The following is a description of a gene set: The gel-like material, with considerable fine structure, that lies in the matrix space, or lumen, of a mitochondrion. It contains the enzymes of the tricarboxylic acid cycle and, in some organisms, the enzymes concerned with fatty acid oxidation. Mouse Gene Set: GOCC_MITOCHONDRIAL_MATRIX species: Mus musculus, and this is the list of marker genes: Cox10, Acadl, Pptc7, Ptpn1, Nudt1, Dlat, Atad3a, Mrps21, Hspa9, Trmt10c, Acadm, Ccar2, Mthfd2, Mrpl40, Acot13, Mrps22, Rad51, Mettl17, Lrrc59, Mrps27, Mterf4, Dld, Rps3, Polg, Nipsnap1, Mrm1, Ywhag, Mccc1, Aurkaip1, Pitrm1, Mrpl17, Bola3, Coasy, Acss1, Top1mt, Pdhb (pyruvate dehydrogenase (lipoamide) beta), Mrpl41, Twnk, Mrps31, Polrmt, Mrpl47, Pccb, Dglucy, Mrpl1, Fech, Mrps18c (mitochondrial ribosomal protein S18C), Snca, Sars2, Gls, Rpusd4, Pdhx, Cps1, Mettl15, Polq, Aco2, Bckdk, Mrps17, 1700066M21Rik, Dhfr, Ngrn, Maip1, Trub2, Ttc5, Sdhaf4, Mrpl58, Acads, Nat8l, Iscu, Mrpl18, Etfa, Mrpl35, Grpel2, Capn10, Mrpl52, Mrpl3, Coq3, Aldh1b1, Pnpt1, Mrpl4, Ppif, Mrps35, Lactb2, Mrm2, Hspa1b, Mrps5, Dnajc19, Pck2, Primpol, Ears2, Nme6, Lrpprc, Hadh, Mrpl49, Acot7, Top3a, Lonp1, Mccc2, Fastkd3, Dnaja3, Tfb1m, Vdac2, Gadd45gip1, Mrpl54, Mrpl9, Dbt, Mrpl2, Dusp21, Lyrm7, Mrpl48 (mitochondrial ribosomal protein L48), Dhx30, Malsu1, Mrpl44, Dtymk, Mterf2, Mterf3, Cs, Mrpl28, Pdha1, Pcca, Ccnb1, Otc, Mrps26, Mterf1a (NCBI Gene Id 78075), Acsm1, Rida, Vdac1, Tbrg4, Dmgdh, Sirt5, Etfbkmt (electron transfer flavoprotein beta subunit lysine methyltransferase), Guf1, Mrps16, Mrps23, mt-Rnr2, Mrps18a, Ndufaf1, Pdha2 (NCBI Gene Id 229888), Slc25a5, Mrpl33, Pcx, Aldh18a1, Exd2, Grsf1, Hmgcl, Acot2, Cdk5rap1, Fastkd1, Sirt4, Pars2, Timm44, Chchd1, Mrpl24, Ogdhl, Mrpl14, Ak4, Mdh2, Hint2, Glrx2, Mrps28, Acadsb, Dnajc15, Mrpl21, Mrpl12, Trap1, Etfb, Csl, Fdx1, Nags, Alas2, Fars2, Flad1, Cox15 (cytochrome c oxidase assembly protein 15), Mipep, Mthfd1l, Shc1, Clpx, Mrps12, Acat1, Mrps9, Pdk1, Mrpl32, Ccnb1-ps, Tfam, Foxo3, Park7, Poldip2, Prorp, Uqcc2, Mrps6, Pdk4, Mpg, Iars2, Tert, Mrpl20, Nipsnap2, Atg4d, Ptcd3, Cbr4, Pin4, Pdk2, Bcl2l1, Mrpl11, Myg1 (NCBI Gene Id 80389), Fastk, Gstk1 (NCBI Gene Id 99356), Iba57, Acaa2, Mrps2, Hspe1-rs1, Mrps30, Oat, Ddx28, Ppm1k, Mrpl15, Nsun3, Sirt3, Nampt, Pgk1, Rpusd3, Cpt2, Pam16, Nars2, Adprs, Lrrk2 (leucine-rich repeat kinase 2), Mtres1, Mrpl38, Mrpl23, Alkbh7, Arhgap11a, Atp5f1b, Mettl4, Spata18, Mrps14, Tufm, Grpel1, Mrpl10, Ethe1, Mrps24, Clpp, Pdpr, Fahd1, Mtnap1, Acot9, Agxt, Tst, Echs1, Mrpl22, Mtg2, Them5, Got2, Dap3, Pde12, Coq4, Nadk2, Creb1, Hadha, Tefm, Trmt5, Nfs1, Mmut, Nsun4, Trmt2b, Bdh1, Fastkd2, Acsm2, Me3, Xrcc3, Angel2, Dlst, Ndufa10, Eral1, Nme4, Hagh, Shmt2, Mrpl57, Hadhb, Acsm5, Bloc1s1, Ndufa9, Mpv17l2, Rcc1l, Mrpl16, Mrps10, Fdx2, Mrps15, Etfdh, Polg2 (polymerase (DNA directed), gamma 2, accessory subunit), Hspa1l, Dars2, Ngb, Mrpl51, Sdhaf1, Mtg1, Hspd1, Mthfd2l, Slirp, Me2, Atxn3, Ak3, Mrpl36, Mrpl13, Pde2a, Glud1, Ssbp1, mt-Rnr1, Tyms, Mrpl34, Hsd17b10, Mrpl37, Trp53, Mrpl50, Dna2, Sdhaf3, Pdk3, Acacb, Slc27a3, Acsm3, Aldh4a1, Mrps18b, Elac2, Ivd, Sod2, Prodh, Casq1, Mrpl42, Aldh2, Cdk1, Acadvl, Mrpl53, Mrps7, Rexo2 (NCBI Gene Id 69180), Mrpl55, Sardh, Fdps, Rtn4ip1, Acss3, Mrpl19, Glrx5, Mrps34, Abat, Hax1, Coq5, Alas1, Mrpl43, Brca1, Hmgcs2, Pyroxd2, Mrpl30, Nmnat3, Nudt8, Hsd17b8, Bckdhb, Yars2, Mrps25, Acsm4, Cbr2, Hspe1, Chpf, Sdhaf2, Pmpca, Wars2, Ptcd1, Eci1, Lars2, Gcdh, Mrpl46, Fpgs, Tfb2m, Abhd11, Mrps11, Prdx1, Mrm3, Mrpl39, Mterf1b, Bckdha (NCBI Gene Id 12039), Pmpcb, Mthfsl, C1qbp, Mrps33, Fastkd5, Mrpl27, Mlycd, Mars2 (methionine-tRNA synthetase 2 (mitochondrial)), Fh1, Tars2, Mthfs, Mrpl45, Acot11, Supv3l1